The following is a description of a gene set: The process in which a uridine in position 34 of a tRNA is post-transcriptionally modified. Human Gene Set: GOBP_TRNA_WOBBLE_URIDINE_MODIFICATION species: Homo sapiens, and this is the list of marker genes: ELP5, URM1 (ubiquitin related modifier 1), CTU1, ELP4, MOCS3, TRMU, DPH3, ELP6, KTI12, ELP3, GTPBP3, MTO1, ALKBH8, TRMT9B, CTU2, ELP1, ELP2